Given this list of marker genes Aph1c, Aph1a, Ncstn, Aph1b, Dner, Adam10, Adam17, Galnt11, Psenen, Psen1, here is a description of the gene set: The series of successive proteolytic cleavages of the Notch protein, which result in an active form of the receptor. Mouse Gene Set: GOBP_NOTCH_RECEPTOR_PROCESSING species: Mus musculus